Given this list of marker genes Enpp1, Vegfa, Ptch1, Alpl, Cab39, Ddr2, Akt1, Cdkn1c, Mgp (NCBI Gene Id 223886), Runx3, Sox6, Thra, Chst11, Plat, Pthlh, Cst5, Slc38a2, Stat1, Mef2c, Runx2, Tgfb1 (NCBI Gene Id 21803), Fgfr1, Igf1r, Pth, Mmp9, Igf1, Serpinh1, Kif3a, Pth1r, Hdac4, Frzb (frizzled-related protein), Adamts4, Mmp13, Bmp7, Calm1, Adamts5, Prkaca, Fgfr3, Igf2, Nkx3-2, Col10a1, Sox5, Scin, Sox9, Tgfb2, Adamts1, Gli3, Hmgcs1, Ctsl, Bmpr1a, Fgf2, Ghr, Ihh, Ift88, Acan, Fgf18, Timp3, Col2a1, Spp1, Stat5b, Plau, here is a description of the gene set: species: Mus musculus Mouse Gene Set: WP_ENDOCHONDRAL_OSSIFICATION Endochondral ossification